Given this list of marker genes Syt10, Vamp1, Unc13b, Nsf, Syt17, Lrrk2, Syt4, Vps52, Stx1b, Napa, Stx19 (NCBI Gene Id 68159), Prrt2, Syt5, Syt7, Vti1b, Sec24d, Gosr2, Syt6, Vps11, Vamp3 (vesicle-associated membrane protein 3), Slc6a4, Syt2, Tmed10-ps, Scfd1, Cplx1, Dapk1, Hectd3, Vamp8, Vps18 (NCBI Gene Id 228545), Grik2, Napg, Kcnb1, Sec24a, Stxbp5, Stx3, Unc13c, Stx2, Baiap3, Stx16 (NCBI Gene Id 99409), Grik1, Stx5a, Exoc3, Txlna, Rnf40, Vps54, Stx12, Abca1, Abcc9, Abl1, Gria2 (glutamate receptor, ionotropic, AMPA2 (alpha 2)), Tnfaip2, Snapin, Golga2, Vamp2, Snap91 (NCBI Gene Id 20616), Snap29, Napb, Capn10, Stx4a, Syt13, Tmed9, Vps50, Snap47, Cplx3, Ankrd27, Snap23, Cplx2, Cav2, Trim9, Stx7, Stxbp2, Cav1 (caveolin 1, caveolae protein), Exoc3l4, Nbas, Sec24c, Cplx4, Txlng, Stxbp5l, Exoc3l2, Stx6, Septin8, Bet1, Syt12, Syp (synaptophysin), Snap25, Syt15, Stx8, Gopc, Septin5, Stxbp3, Snca, Syt1, Sec22b, Tmed10, Syt11, Cacna1a, Tpcn1, Rab4a, Exoc3l, Stxbp4, Doc2b, Stx11, Stx17, Sec24b, Syt3, Adcy6, Txlnb, Stx1a (NCBI Gene Id 20907), Myo5a, Picalm, Unc13a, Ptpn2, Syt9, Syt8, Stxbp1, Uvrag, Vamp9, Vti1a, here is a description of the gene set: Binding to a SNARE (soluble N-ethylmaleimide-sensitive factor attached protein receptor) protein. Mouse Gene Set: GOMF_SNARE_BINDING studied in species Mus musculus